Given this list of marker genes Runx2, Cbfb, Ar, Smad1, here is a description of the gene set: Reactome Pathway: RUNX2 regulates bone development electronically inferred by orthology from the curated human pathway This event has been computationally inferred from an event that has been demonstrated in another species.<p>The inference is based on the homology mapping from PANTHER. Briefly, reactions for which all involved PhysicalEntities (in input, output and catalyst) have a mapped orthologue/paralogue (for complexes at least 75% of components must have a mapping) are inferred to the other species. part of: Transcriptional regulation by RUNX2 species: Mus musculus